The following is a description of a gene set: species: Mus musculus Mouse Gene Set: GOMF_INOSITOL_1_4_5_TRISPHOSPHATE_BINDING Binding to inositol 1,4,5 trisphosphate., and this is the list of marker genes: Trpc6, Plcd1, Trpc4, Itpr2, Trpc7, Itpr1, Trpc2, Trpc5, Plcl2, Trpc1, Cyth2, Rph3a, Trpc3, Itpr3 (NCBI Gene Id 21779)